The following is a description of a gene set: Neoplasm of the tracheobronchial system studied in species Homo sapiens Human Gene Set: HP_NEOPLASM_OF_THE_TRACHEOBRONCHIAL_SYSTEM, and this is the list of marker genes: BRAF, PPP2R1B (NCBI Gene Id 5519), PIK3CA, MAP3K8, CASP8, COL4A5 (NCBI Gene Id 1287), PRKN, KRAS, CYP2A6, FASLG, TERT, SLC22A18, COL4A6, MUC5B, IRF1, ERBB2, SFTPA2, EGFR, DICER1, ERCC6, SFTPC, KEAP1 (NCBI Gene Id 9817)